The following is a description of a gene set: Human Gene Set: OSF2_Q6 species: Homo sapiens Genes having at least one occurrence of the motif ACCACANM in the regions spanning 4 kb centered on their transcription starting sites. This matches the RUNX2 transcription factor binding site V$OSF2_Q6 (v7.4 TRANSFAC)., and this is the list of marker genes: ELAVL3, GPRC5C, SOX2, FLT3, PICALM, TBX5, DPH1, CHSY1, COMMD3, MND1 (NCBI Gene Id 84057), CNIH3 (cornichon family AMPA receptor auxiliary protein 3), AZIN1, TSPAN17, DYRK1B, SUPT16H, KCTD15, CCNQ, HOXB5, EDC4, ID2, ITPR1, PAX1, KLHDC9, AFF4, KRAS, CLCN3 (chloride voltage-gated channel 3), ACIN1, CYP2A7, HP, BLOC1S1, SWT1, ZBTB18, LINC00314, GPD1, WNT6 (Wnt family member 6), HNRNPUL1 (NCBI Gene Id 11100), SPEM1, CSNK1G3, OTOGL, FGF4, HEY1, SLC31A2, KDM5C, ZNF775, ARF3, ZNF532, NRAS, SIRT1, MSRA, KCNMA1, DLX2, GARIN3, SAP30L, RDH5, FGFR1 (NCBI Gene Id 84151), INHBA, PHF12, CSF2, IDO1, ATP6V0A4, SRP14, ELAVL2, RNF122, ZNF654, IL3, AKT2, IL17A, ZDHHC9, CASS4, TP63, MEX3B, ITGA10, NOL4L, KMT2E, PAPOLG, PHF6, SPIB, PROKR1, AMD1, NEUROD1, ZNF362, CPA2, NCAM1, GRHL3, KLHL5, CACNA2D3, LRATD1, CHN1, STC1, PCSK5, RPA2, ZIC4, UMOD, MTMR11, GPR15, SREBF2, MGP, CCDC91, DAB2 (DAB adaptor protein 2), ETF1, SRRM1, LMOD1, PTPN22, TSGA10, CSNK2B, NIBAN3, PURG, CELF4, AKAP13, SMAD9, FERMT2, IL16, TULP4 (TUB like protein 4), TCF12, STAG1, RGS14 (NCBI Gene Id 10636), MTF1, RAB11B, PLEKHA6, PRDM10, LRTM1, AGPAT4, HIPK1, ERG, VASN, PCDHA1, PIGV, THAP7, SKIDA1, SLC26A6, BCL6, EMSY, ZIC1, RIN1, HAPLN1, SDF2L1, HPCAL1, FGF10, OMG, SIN3A, PPP1R12C, MMP13, PEA15, C1QTNF6, TSC22D1, TAF6, MRPL14, OTP (orthopedia homeobox), ABCD4, PIK3R3, ASCL4, MTMR4, GPANK1, COA3, THAP7-AS1, C14orf119, MANEAL, TWF1, RGMA, ADAMTS8, SLC6A9, RNF24, VPS45, MINDY2, CORO1C, TRMT1L (tRNA methyltransferase 1 like), WNT7B, TRAF4, LINC00955, BRPF1, FDCSP, TBC1D10B, CEP70, ZHX2, CNPY4, NKX2-2, AGO1 (argonaute RISC component 1), MAP3K13, RUNX2, MMP14, HOXB3, HOXB6, POU2F1, DMPK, PRRG4, SLC26A7, DPYSL5, KCNJ1, GPBP1L1, SPINK5, TCF4, WRN, APCDD1L, CNTD1, LEMD2, PI15, CXCR5, ROGDI, C11orf42, LMO3, SRSF8, DKK1, ZBED10P, FST, FAM13C, MSI2, FGD1, GREB1L (GREB1 like retinoic acid receptor coactivator), IL17F, FAM53B, SGK1, SLC8A1, MTMR3, TMEM86A, RAB27A, ZBTB8A, CCDC177, IL7R, APOBR, NGEF, HSP90B1, NOL4, AKAP8, ZNF485, DUSP13B, HOXB4, ATP6V0A1, EVA1A, NEUROD2, MYOCD, OLIG3, RBMXL2, RUNX1, IL1RAPL1, NKX2-1, TSC22D3, JMJD1C, NDNF, SPAG9, TOB1, PROK2, STC2, NLK, SYNE1, SRSF6 (serine and arginine rich splicing factor 6), KCNV2, ADGRB2, COL2A1, PPP1R14C, KRT10-AS1, NOB1, EVI2A, DACH2, GPX1, SLA2, MAP1LC3A, HOXA5, PAFAH1B1, IFNG, NUDT3, LPXN, RPP21, REL, PITX2, MACROH2A1, P2RY10, PRRX1 (NCBI Gene Id 5396), ATP2A2, HOXD10, RHOQ